Given this list of marker genes MGAT1, PMEPA1, PPP2R3A, MARCKS, SEC61B, ESM1, ARID3A, ZCCHC18, RAB20, PAWR (pro-apoptotic WT1 regulator), MIR22HG, WRAP73, DNAJC1, SCIN, GPX8, DSG2, SLC16A10, GPR171, F2R (NCBI Gene Id 2149), F2RL2, SLC4A7, TBC1D10B, RYK, TOX2, ADORA2B, VKORC1, SMIM3, RTKN, LPGAT1, MRPL35, NXNL1, JDP2, RNPEP, IGHG1, EHBP1L1, SLC35F2, ASNS (NCBI Gene Id 440), PDCD1, LRP10, DDX3Y, SLC7A4 (NCBI Gene Id 96585), EVI5, TSEN54, LPXN, LGALS3, AHR, ABCC1, STAU2, CEP162, SOAT2 (sterol O-acyltransferase 2), STAT3 (NCBI Gene Id 6774), GEM, RNF217, CEBPB, OCIAD2, SDF4, SLC25A53, NEDD4, SOAT1, IL1R2, TNFRSF18, UTY, ARMCX3, SPA17, VMP1, HIC1, RBPJ, STK3, SH2D2A, KTN1, GPAA1, ATXN3, KCTD11, LYPLAL1, USP47, AUH, FUOM, MAF, MLKL, TMTC2, IL12RB1, KIF3A, VCPKMT, MED12L, PLAGL2, SHTN1, DUSP5, PSME2, PRDM1, STK16, CST7, WDFY2, DOK2, CYSLTR1, PDE6G, SPSB1, ICOS, ITPRIPL2, GLRX, MYO10, RNF19B, PAXBP1, GSTM3, LGALS1, GZMA, BMI1, TRMO, AOPEP, FRMD4B, ACYP2, CDC73, DUSP14, SAMSN1, NT5M, GLMN, NABP1, STX11, SUGT1, CASP4, SKAP2 (src kinase associated phosphoprotein 2, NCBI Gene Id 8935), ASB2, IL4, PLEKHF1, RAB1A, CHST11, MLEC, DNAJB6, CASS4, MS4A7, AKAP7, TMED3, SLC30A2, FOCAD, RGS1, EHD1, TNFSF13B, SLC39A4, ALS2, TAF12 (NCBI Gene Id 6883), UBXN2A, APRT, TMED5, XKR8, TASL, RPS6KA6, CYP11A1, BCL2A1, PSMB10, ENPP1, CDYL2, GSPT2, RNF152, GNPTAB, DNAJA4, RUNX2, FCHSD2, ELL2, EBI3, UCP2, DYNLT5, MAP2K3, PLS3, MTFMT, DGAT1, PTPN3, SPP1, ITPR1, SMPDL3B, MARVELD2, SUSD3, UBE2E3, CIB2, PRXL2A, PSME4, CLDN12 (claudin 12), EPAS1, NAA20, DNASE1L3, TMEM62, TNFSF10, HK3, SDHAF2, JCAD, BASP1, GGH, RAP1A, RNH1, TAPBPL, POLDIP3, SV2C, TNFRSF4, CD8A, ZNF131, PLIN2, PNPO, RPS6KA5, IL10, TMEM132A, TMBIM4, C12orf75, here is a description of the gene set: Human Gene Set: GSE7460_FOXP3_MUT_VS_WT_ACT_TCONV_UP The transcription factor Foxp3 is usually considered the master regulator for the CD4+CD25+ Genes up-regulated in comparsion of sfActCD4 versus ActCD4 (see Fig. 1 in the paper for details). from publication Hill JA, Feuerer M, Tash K, Haxhinasto S, Perez J, Melamed R, Mathis D, Benoist C (PMID 18024188) species: Homo sapiens